The following is a description of a gene set: An anomaly of the intra-atrial or intraventricular septum. Human Gene Set: HP_ABNORMAL_CARDIAC_SEPTUM_MORPHOLOGY studied in species Homo sapiens Abnormal cardiac septum morphology, and this is the list of marker genes: NDUFB7, TBX20, VPS35L, SMC1A, TBX22, RAD21, CDK13, ALKBH8, MYRF, GNAO1, SMAD4, MRAS, CASK, PIEZO2 (NCBI Gene Id 63896), PEX26, MKS1, DPH2, MYOCD, SPEN, SHMT2, CASZ1, IRX5, TBL2, ODAD3, SNX14, ELN, DBR1, PKD1L1, NEUROD2, AKT3, ATIC, TGFB3, WAC, ARCN1, PIGT, RRAS, CFAP53, ARSL, FANCA, SYT1, TRRAP, PKDCC, TBX3, HNRNPR, SPECC1L, NOTCH3, ACTA2, AARS1, MRPL3, TAF6, AUTS2, PEX11B, FOXF1, AFG2A, FBXO11, SLC29A3 (solute carrier family 29 member 3), TRIP4, RPS15A, IFT27, KCNA1, SF3B2, RELN, TRAF7, PGAP1, ZFX, SNRPN, TIAM1, UBE4B, EXT2, SCN2A, GATA1, FANCI, SYNE1 (NCBI Gene Id 85448), RAD51, BUB1B, HCCS, BICRA (NCBI Gene Id 29998), CDH2, DSE, STRA6, GPC3, RAD51C, SOX2, MYH6, PAX3, FANCE, GNPTAB, FILIP1, TSR2, DSG1, SCAF4, SH2B1, RTL1, ROR2, PALB2, TKT, ANKRD11, FADD, PRDM16, KIF11, EIF4H, AHI1 (NCBI Gene Id 54806), ZNF462, LUZP1, RPS17, SOX4, H3-3B, COG6, ACVR2B, GPC4, TBX1, FGFR3, VPS33B, TGFBR2 (NCBI Gene Id 7048), KIF7, NONO, ARX, MYPN, EBF3, IPO8, NKX2-1, FRA10AC1, ASXL2, TCTN3 (NCBI Gene Id 26123), CSGALNACT1, MKKS, VEZF1, DPH5, COX7B, RNF113A, DNA2, ARVCF, NRAS, ALDH1A2, POLR1A, WNT4, UBE3B, NAA10, CEP57, ZDHHC9, SMAD6, DLG5, MYH3, TBX2, AMMECR1, ARID1B, CHD4, CTU2, NAA20, SMG9, DHCR7, FOXC2, BMP2, RPL9, SKIC2, PTEN, GJA5 (gap junction protein alpha 5), GLA, LONP1, SDHD, BUB1, GDF6, DYNC2LI1, MID1, HDAC8, RPL35A, FKBP6, UMPS, WT1, FANCB, CLIP2, TALDO1, NIPA1, MPDZ, MEIS2, H3-3A, DNAH9, ZMPSTE24, CRB2, SF3B4, HSPA9, PORCN, SIK1, IDH1, NIPBL, B3GALT6, RPL3L, PNKP, G6PC3, ARID2, CWC27, UPF3B, DCPS, RERE, VPS13B, SCUBE3, ERCC2, DVL1, HAAO, DDX11, MAD2L2, PSMD12, FANCD2, SLC32A1, MPL, NXN, OTUD6B, EVC2, TMEM94, GRIN1, UBE2A, RPS29, SALL4, DACT1, CLCN3, STX1A, ECHS1, YY1, PRKD1, NF1, TAPT1, CCDC32, CDKL5, RAP1B, WLS, MMP2, OTUD5, ZMYM2, BRD4, EP300, LMNB1, MED23, SMARCA4, TARS1, MYMK, SATB1, MAP2K1, RAB34, TXNL4A, RPS7, POGZ (NCBI Gene Id 23126), HEATR3, MMP23B, HOXD13, BRF1, RPL10, ASXL1 (NCBI Gene Id 23393), FANCL, ARHGAP31, CEP295, MYL2, KMT2A, ARID1A, CITED2, SMAD3, THSD1, RECQL4, NIPA2, DST, FGFR2, TBC1D24, PPFIBP1, LETM1, SOS2, CALM3, DMXL2, CDK10, FUT8, FBXW11, KLHL41, DPYSL5, FGFR1, EOGT, CHRM3, ALPK3, PEX12, GATA6, CANT1, RYR1, EHMT1, RPL15, RNU4ATAC, ATP9A, CRKL, H4C9, PDHA1, COL1A1, WDR37, GTF2H5, BCR, UFD1 (NCBI Gene Id 7353), PEX1, RPL18, XRCC2, MCTP2, THPO, TMEM260, PGAP2, MICU1, USP18, COG1, SEC24C, DDX59, RRAS2, ZBTB7A, IFT81, KAT5, CKAP2L, PQBP1, THOC6, WDR26, ATP6V0A2, RBM8A, FANCF, PIGA, RSPO2, CTBP1, ESCO2, BMPR1A, GET3, VIPAS39, KAT8, TLL1, MACF1, FOXP2, MIR17HG, ATP6V1A (ATPase H+ transporting V1 subunit A), IFT172, DTNA, NELFA (negative elongation factor complex member A), B3GAT3, PTF1A, FGFRL1, SLC35A2, CCBE1, CYP27A1, TNFRSF11A, FRMD5, PLD1, PDPN, FTO, MYCN, PRKCZ, AFF4 (ALF transcription elongation factor 4), CUX1, EXOC2, AGO2, SLC25A22, LARP7, HNRNPU, TTC7A, MEOX1, KIAA0586, DNAJC19, LBR, MMP14, DLL4, CEP290, TRIP13, PPP1CB, TGFBR1, DPF2, SRCAP, RREB1, FANCC, CTCF, ESAM, FTCD, SMAD2, MTX2, STX5, COMT, ZNF699, PRDM13, ATN1, CHST3, SIK3, RPL31, KDM3B, LRP2, MAPKAPK5, SHOC2, KDM5A, RPS20, GATA5, SLX4, NCAPG2, XYLT2, FOXC1, SZT2, SNRPB, NEK9, PIGO, ANAPC7, PLXND1, TAB2, SUCLG1, TMEM270, NPHP3, GTF2E2, CCDC47, RPL35, DYRK1A, NKX2-6, LEMD2, SOX11, ATP2B1, MEGF8, GPC6, COG7, STAG1, RAB23, GRM7, ZNF341, CUL3, PRR12, MGP, HACD1, PPP1R21, PRKACB, TRAIP, GATA4, INSR, CDC42, IFT56, FLNB, ERBB3, RRAGC, SETD1A, PIGG, ERI1 (NCBI Gene Id 90459), RPS27, MAP3K7, RPL26, NDUFB11, GTF2I, RFC2, ABL1, ZNF668, ADAMTS10, ALG8, KCNH1, RBM10, FGF13, KATNB1, TRIM8, PAH, TUBG1, TNNT2, HNRNPH2, SLC38A3, RPS19, GABRD, SON, SLC37A4, BRAF, ROBO1, FOCAD, TET3, DEF6, SMN1, BBS2, RFWD3, SCN1B, METTL5, IGF1R, NKX2-5, MED13L (mediator complex subunit 13L), FLI1, BUB3, NSDHL, PIGQ, SOS1, MAX, CHST14, RARB, TCIRG1, CHMP1A, PIEZO1, HIRA, BRCA2, ECE1, GCSH, GDF3, MEG3, NAE1, BAP1, SMARCB1, NSD1, AXIN1, SPTBN1, SIX6, RPS24, PI4KA, PUF60, MLXIPL, MMP21, RMRP, ERCC4, CLXN, PEX14, PEX10, XYLT1, EPHB4, EIF4A2, ADAT3, CFC1, B3GLCT, TBX5, CRELD1, COQ4, DLK1, BUD23, NEDD4L, KAT6B (lysine acetyltransferase 6B), MOGS, CD96, CARS1, ADA2 (adenosine deaminase 2, NCBI Gene Id 51816), JAM3, CFAP45, PTPN11, DGCR6, GTF2IRD2, LTBP4, PGM1, H4C3, MAP2K2, TMEM237, ROBO4, UQCRFS1, KDM1A, TMEM147 (NCBI Gene Id 84721), MED25, KCNAB2, LIMK1, PSMC1, CHD3, CSRP3, MAGEL2 (NCBI Gene Id 54551), FBXL4, GLI3, BRCA1, ACTC1, ITPR1, TRIO, GP1BB, USP9X, SLC25A24, NOTCH1, DVL3, PIGN, GJA1, TSFM, WBP4, DMPK, FLNA, PEX3, DGCR2, HRAS, KIF15, TAOK1, RPL5, MGAT2, TMCO1, DGCR8, PIK3R2, TBX4, RPL8, STAG2 (STAG2 cohesin complex component), CDK8 (cyclin dependent kinase 8), PRKACA, NDE1 (nudE neurodevelopment protein 1), SPRED2, STK4, CCDC22, ESS2, SEC31A, VPS37D, SETD5, MAPK1, HSPG2, ABCD4, VAC14, PIK3CA, GDF1, NR2F2, ALG9, SMARCD1 (NCBI Gene Id 6602), NUP107, NODAL, DNAJC30, CCDC174, WASHC5, FLCN, KRAS, SMARCE1, ADNP, UBR7, VPS33A, FBN2, CCND2, MBTPS2, MT-CYB, PRRX1, FH, RNU4-2, FANCM, CAMK2A, ZIC3, KDM6A, ZEB2, AGGF1, SIAH1, CBL, MASP1, COL11A1, MED11, SMC3, HYMAI, MYH7, NSD2, EPG5, KIFBP, RIT1, RFX7, LMNA, PEX2, SEMA3E, WBP11 (NCBI Gene Id 51729), FBN1, SLC19A2, DDX3X, FLII, EFTUD2, RPS28, NUP188, KMT2D, YY1AP1 (NCBI Gene Id 55249), PEX13, RPS10, INTU, TFAP2B, RAC1, BAZ1B, ADAMTS17, IGBP1, ASCC1, RAF1, HOXA13, BCOR, LAMA5, DNMT3A, SKI, PIGP, FIBP, GLI1, KDM5B, PEX16, LRP5, RIPK4, DOHH, LTBP2, AMER1, CHD7, WDR35, CPE, BSCL2 (BSCL2 lipid droplet biogenesis associated, seipin), LARS2, NEK1, ACADVL, PEX19, JMJD1C, NOTCH2, FIG4, ODAD1, PACS1, UBE2T, YARS1, PHGDH, RASA2, DYNC2I1, RPL11, CCNQ, CACNA1D, NCF1, PACS2, BRIP1, COL1A2, SLC12A2, PPP2CA, STRADA, GTF2IRD1, TMEM53, C2CD3, DDX6 (DEAD-box helicase 6), SUPT16H, PCGF2, METTL27, PPP1R13L, TASP1, GNB2, CIROP, WNT3 (NCBI Gene Id 7473), UQCRC2, SALL1, APC2, FKTN, TBCK, KAT6A, STAT1, PPP2R5D, LMBRD1, HNRNPK, SH3PXD2B, SVBP, PLAGL1, RAI1, UBR1, ATRX, PRIM1, MYBPC3, EIF2AK3 (NCBI Gene Id 9451), UFC1, SHANK3 (NCBI Gene Id 85358), WDPCP, ANK1, PCNT, TPR, SMARCC2, MPLKIP, DAW1, SATB2, PEX6, GPX4, SMG8, EVC, CDC45, FANCG, PLCH1, CDC42BPB, ALG12, AHDC1, PIGF, PEX5 (peroxisomal biogenesis factor 5), GYG1, RPS26, NKAP, NFE2L2, ADK, RPL27, SKIC3, HYLS1, CACNA1C, CPLX1, CREBBP, SLC25A36, NFIX, POLA1, ERCC3, SETBP1, MTFMT (NCBI Gene Id 123263), TWIST1, DPH1, POR, JAG1, OCLN, ATP6V1E1, TGDS, RSPRY1, GNB5, TP63, PIGL, KANSL1, STAMBP (STAM binding protein), SLF2, GJA8, NDUFC2, LZTR1, POLR3A, MED12, PPM1D